The following is a description of a gene set: Human Gene Set: GSE26030_UNSTIM_VS_RESTIM_TH1_DAY15_POST_POLARIZATION_UP Genes up-regulated in Th1 cells 15 days post polarization: control versus stimulated with anti-CD3 and anti-CD28. studied in species Homo sapiens Serial comparison between Th1 and Th17 tumor-specific cells cultured in vitro and ex vivo after transferred into sublethaly irradiated B6.PL mice. Th17-derived cells acquire Th1-like properties in vivo but maintain a distinct molecular profile. from publication Muranski P, Borman ZA, Kerkar SP, Klebanoff CA, Ji Y, Sanchez-Perez L, Sukumar M, Reger RN, Yu Z, Kern SJ, Roychoudhuri R, Ferreyra GA, Shen W, Durum SK, Feigenbaum L, Palmer DC, Antony PA, Chan CC, Laurence A, Danner RL, Gattinoni L, Restifo NP (PMID 22177921), and this is the list of marker genes: SAMSN1, SLC29A1, HGH1, HAUS5, NIPSNAP3A, RCAN1, GPR35, SREBF2, FAM20A, CLIC1, RAB19, CCND2, PPM1B, RETREG1, SRPK1, ACP2, ACP5, ZNG1B, ACSS1, LPCAT2, SEPTIN6, SMC4, ZMAT1, EEIG1, PPP2R1B, NFAT5, COL4A2, LRRC8C, STT3B (NCBI Gene Id 201595), RSAD1, SOCS3, BAHD1, RNF166, ITGAL, IL2RG, LSM3, TCF7L2, HLA-B (major histocompatibility complex, class I, B), BIRC6, ETFA, BCL2, MKNK2, DONSON, SCNN1A, ARAP1, RRM2B, HTRA2, SH2D3C, SLAMF9 (SLAM family member 9), AP4S1, ZFAND3, SPRED1, TNFRSF1B, SEPTIN7, PTK2B, LDHA, HMGB1, MYO18A, UCKL1, SGMS1, PSMD14, ACOT9, CST3, GPX1 (glutathione peroxidase 1), HIP1, HLA-DRB1, NFE2L2, KPNA4, TGFBR2, FAM219B, PDLIM7, AAAS, RBBP7, PECAM1, B2M, MDC1, CEACAM21 (CEA cell adhesion molecule 21), FRMD8, YWHAZ, ARL6IP1, VASP, CYFIP2, FZD7, LTA4H, KIF20B, NRARP, AZIN1, MAPKAP1, BCL6, APOBR, KCTD16, UBC, CD68, SNX14, DLG1, CDIPT, DNAJC9, MFAP1, STK24, TMED5, PDGFB, CYB5R3, RRAS, SPN, OXR1, PTPN12, RGS3, HEXIM1, RASSF5, FBXO28, B4GALT5, ARF6, MAP3K14, PILRA, FCER1G, IFRD1, ETS2, SPATA13, TREM1 (triggering receptor expressed on myeloid cells 1), MCM5, GNPNAT1, ARHGAP39, PHTF2, C1orf35, TGM2 (NCBI Gene Id 7052), PDCD1LG2, AKT1, CD47, TUFT1, SLC39A13, PPM1H, LONRF1, SPRED2, GK, CCDC88C, ZBTB16, SLC44A2, PHLDA3, ACER3, LIPE, SERPINB6, AGPAT4, NUPR1, SMAD3, RUNX2, ITGB1, SLC11A1, GJB2, IGF2R, GEMIN4, TMCO1, DENND3, FYN, TMEM121B, ENO3, MAP4K3, SKIL, MED7, JUP, STUB1, LRP10, CEBPB, CRLF2, PDHA1, PIEZO1, NUP107 (nucleoporin 107), MAPRE1, SH2D1B, EZR, CHD3, ATG4D, DEF6, ZNF808, CKS2, PGLYRP1, NAPSA (NCBI Gene Id 9476), PPP1R8, TGM3, APOC2, HMGA1, CENPC, STAT3, MYO1G, PILRB, TRPM2 (NCBI Gene Id 7226), NID2, THBD, KLF4, RHOF, PIP4K2C, BAZ1A, CDYL, INPP1, NUAK2, JPT1, EVL (Enah/Vasp-like), RTN1 (NCBI Gene Id 8108), CYP4F3, IL31RA, PIP4K2A (phosphatidylinositol-5-phosphate 4-kinase type 2 alpha)